The following is a description of a gene set: Portion of the axon proximal to the neuronal cell body, at the level of the axon hillock. The action potentials that propagate along the axon are generated at the level of this initial segment. Human Gene Set: GOCC_AXON_INITIAL_SEGMENT studied in species Homo sapiens, and this is the list of marker genes: KCNA2, NRCAM, IQCJ-SCHIP1, LRRC7, ANK3, SCN2B, SCN1A, SPTBN4, SCN8A, KCNQ2, MAP1A, LGI1, BIN1 (bridging integrator 1), TRIM46, KCNQ3, CLCN2, MAP2, NFASC, NAV1, CNGA3, KCNA4, KCNA1, CNTN2